Given this list of marker genes DAGLA, MGLL, ABHD12, ABHD6, DAGLB, here is a description of the gene set: Human Gene Set: REACTOME_ARACHIDONATE_PRODUCTION_FROM_DAG studied in species Homo sapiens Arachidonate production from DAG